The following is a description of a gene set: Human Gene Set: HP_LINGUAL_DYSTONIA Involuntary protrusions, movements, spams and contortions of the tongue. Lingual dystonia species: Homo sapiens, and this is the list of marker genes: ATP13A2, NGLY1, GNAL, THAP1, VPS13A